Given this list of marker genes SPG21, DRD2 (dopamine receptor D2), CUX2, MAPK10, TOR1A, CHD2, DNM1 (NCBI Gene Id 1759), SCN1A, GABRB3, KCNT1, CYP27A1, SGCE, WAC, RORA, KCTD17, XK, CACNA1A, CBS (NCBI Gene Id 875), here is a description of the gene set: A personality disorder is a deeply ingrained pattern of behavior of a specified kind that deviates markedly from the norms of generally accepted behavior. It is typically apparent by the time of adolescence and causes long-term difficulties in personal relationships or functioning in society. Human Gene Set: HP_PERSONALITY_DISORDER Personality disorder species: Homo sapiens